The following is a description of a gene set: This study aimed to identify gene expression markers shared between both influenza hemagglutination inhibition (HAI) and virus-neutralization antibody (VNA) responses. We enrolled 158 older subjects who received the 2010-2011 trivalent inactivated influenza vaccine. Influenza-specific HAI and VNA titers and mRNA-sequencing were performed using blood samples obtained at Days 0, 3 and 28 post vaccination. For antibody response at Day 28 versus Day 0, several gene sets were identified as significant in predictive models for HAI (n=7) and VNA (n=35) responses. Five gene sets (comprising the genes MAZ, TTF, GSTM, RABGGTA, SMS, CA, IFNG and DOPEY) were in common for both HAI and VNA. For response at Day 28 versus Day 3, many gene sets were identified in predictive models for HAI (n=13) and VNA (n=41). Ten gene sets (comprising biologically related genes, such as MAN1B1, POLL, CEBPG, FOXP3, IL12A, TLR3, TLR7 and others) were shared between HAI and VNA. These identified gene sets demonstrated a high degree of network interactions and likelihood for functional relationships. Influenza-specific HAI and VNA responses demonstrated a remarkable degree of similarity. Although unique gene set signatures were identified for each humoral outcome, several gene sets were determined to be in common with both HAI and VNA response to influenza vaccine. Genes up-regulated in peripheral blood mononuclear cell 28d vs 0d in adults (50-74) (in common with both HAI and VNA) after exposure to Fluarix, time point 28D, administered i.m.. Comment: Common Genesets with genes entering regression models for HAI and VNA Responses with the log2 Day 28 vs Day 0 fold-change in gene expression as the explanatory variables. from publication Ovsyannikova IG, Salk HM, Kennedy RB, Haralambieva IH, Zimmermann MT, Grill DE, Oberg AL, Poland GA (PMID 27534615) Human Gene Set: OVSYANNIKOVA_PBMC_FLUARIX_AGE_50_74YO_COMMON_WITH_BOTH_HAI_AND_VNA_28DY_VS_0DY_USED_IN_HAI_AND_VNA_RESPONSE_MODELS_UP studied in species Homo sapiens, and this is the list of marker genes: SUPT16H, DOP1B, IFNG, UPF1, RABGGTA, MAT2A, CA8